The following is a description of a gene set: species: Homo sapiens Human Gene Set: GOCC_GOLGI_APPARATUS A membrane-bound cytoplasmic organelle of the endomembrane system that further processes the core oligosaccharides (e.g. N-glycans) added to proteins in the endoplasmic reticulum and packages them into membrane-bound vesicles. The Golgi apparatus operates at the intersection of the secretory, lysosomal, and endocytic pathways., and this is the list of marker genes: WDR81, B4GALNT4, GABARAPL2, MAN2A1, ST3GAL5, BECN1, DAPK2, LAPTM4A, LPCAT2, ZDHHC5, TSNAX (translin associated factor X), CIMAP3, TRIM22, ARL5C, COP1, TLR8, ZDHHC15, TRAPPC1, MUC7, GNAQ, B4GALNT3, AKT3, ST3GAL6, BIRC6, TRIM23, GCNT1, CABP1, GASK1A, UXS1, PYCARD, NOTCH4, GARIN4, NEDD4L, MAP4K2, MTUS1 (NCBI Gene Id 57509), HLA-DQA1, GORASP2, NUBP1, VAMP7, PPP2R3C, ATP6V0A1, VRK1, AP1M2, GPR107, TPPP, SLC29A3, TAPBPL, GOLT1B, GAPT, RND3, SPRY1, CLTCL1, PI4K2B, SPATA16, ACTL7A, RAB6C, COG5, SEC16B, CLU (clusterin), YIPF3, CACFD1, ATP6V0C, APH1A, SART1, TMEM241, ZDHHC13, ARHGAP32, ATP11A, OPTN (NCBI Gene Id 337928), STEAP2, GOLGA6B, MYMK, RAB3GAP1, DAG1, TRAPPC14, SLC9A7, CD2 (CD2 molecule), TMEM230, CABP2, TPST2, CALN1, FZD8, MBTPS1, TMEM167B, GCNT2, DDX54, FAM241A, ATP8B2, SPPL3, VPS13A (NCBI Gene Id 23230), YIPF4, ENTPD4, LMTK3, VTI1A, CD1C, SCYL1, PISD (phosphatidylserine decarboxylase), CLASP2, MID1, RASIP1, YIPF5 (NCBI Gene Id 81555), SPRR3, KIFAP3, TBC1D22A, ST3GAL3 (NCBI Gene Id 6487), MOSPD1, ARV1, TMEM30A, FAIM2, PLIN3, CD59, JAKMIP2, LEPROT, ATP1A1, PKN3, HS3ST2, GOLGA8B, SCAP, DEFB103B, HID1, CSNK1D, TMCO1, WDR44, STX4, CCDC186, SH3GLB1, GDI1, SRCAP, PITPNB, HLA-H, JAM3, ARF5, DENND4C, ERO1A, SLC10A7 (solute carrier family 10 member 7), COPG1, RAPSN, MANEA, AGRN, MMP11, RAB25, COG7, STMN3, PLSCR1, FCMR, HLA-G, GALNT3, SLC30A1, UNC13B, GDNF, CRHBP, FBXW8, RPGR, C11orf24, RNF24, SLC35A1, ATP2C2, MTCL2, TMF1, WNT5B, M6PR, NOS3, GOLGA8CP, PDGFD, CD3E, FYCO1, MGAT3 (beta-1,4-mannosyl-glycoprotein 4-beta-N-acetylglucosaminyltransferase), MARCHF2, P3H2, BMP1, AKR7A3, WLS, SLC26A11, TNRC6A, FAM114A1, MAP2K2, TLR9, SLC18A3, SEC23A, PANX2, SLC35E2A, ST6GALNAC6, MUC20, LARGE2, TGFB1, CD33, MGAT4A, CDK5RAP2, DIPK2A, TMBIM4, GAD2, SGCD, DEFB103A, GALNT14, MOSMO, DHH, RICTOR, GBGT1, ANGPTL3, PPP1R15A, RHBDF1, ITGA5, RAB11FIP4, TMED9, PAQR8, RAP1GAP, GGA3, GABARAPL1, NAA25, G2E3, GOSR1, CLVS1, SLC35D2, PMF1, MARCHF8, GORASP1, PKD2, STK16, SI, GBP5, AP3B1, RNF121 (ring finger protein 121), TMC6, PI4K2A, SDE2, GOLGA3, MUC4, NIPAL1, DHCR24, SYNE1, B3GALNT1, TRAPPC6B, VIPAS39, KIF13A, GOLGA8R, SSPN, CHST2, NTN3, TMEM87A, B4GALT2, GJA1, PTPRN, RAB14, PDGFC, TRAPPC12, TNKS, RAB26, B3GNT3, VPS13B, B4GALT7, IPO5, MAPK8IP3, GBP4, STX10, FAM234B, MUC12, AMFR, GLT8D1, SNAPIN, GAL3ST1, CCN2, ATP9A, TVP23B, DENND5A, GRM6, STK24 (serine/threonine kinase 24), RHOBTB3, MS4A7, SLC39A11, A3GALT2, RAB11A, APH1B, PROZ, LMAN2L (lectin, mannose binding 2 like), CAV3, MGAT1, IFITM1, APOO, SDC4, MAPK3, SEC14L1, SLC39A7, VPS52, PCSK9, SLC30A7, KDELR2, SGCA, AOC3, LAMP2, BACE2, APBB2, CLVS2, KDELR3 (KDEL endoplasmic reticulum protein retention receptor 3), GALNT8, FGD1 (FYVE, RhoGEF and PH domain containing 1), GLB1, MGAT5B, COPG2, TMEM130, ATP2C1, TICAM2, PKMYT1, GPC6, RAB1B, SLC30A6, RNF115, UBXN2A, FHDC1, MUC6, OPRM1, HRAS, HAS3 (NCBI Gene Id 3038), RIC3, PTCH1, SELENOI, GPR108, POSTN, RAB33B, PKDCC, ARCN1, CTTN, PSEN2, B4GALT5, CD14, BICD2 (NCBI Gene Id 23299), SYNDIG1L, MPPE1, SREBF2 (sterol regulatory element binding transcription factor 2), MOB4, PROC, TJAP1, LRBA, ACBD3, HEPACAM2, NOSIP, ZDHHC6, TBC1D23, PDGFRA, GBP3, DEFB1, ATP6AP2, SEC23IP, WNT7A, LRP6, MTOR, YIF1A, TBC1D4, HLA-DQB2, RAD23A, STX12, B3GALNT2, CD36, PLK3, COPZ2, CST7, GOLGA8Q, MUC13, MYDGF, NAA60, SCOC, ENPP7, ZDHHC3, FTCD, NBN, STK25, TRAPPC13, AGTRAP, COG8 (component of oligomeric golgi complex 8, NCBI Gene Id 84342), CHSY1, APP, CFP, DEFA1B, ARL17B, DUX4, FUT8 (NCBI Gene Id 2530), DCLRE1C, GALNT7, HTT, AGPAT3, GOLT1A, RABEPK, PGAP4, HS3ST3A1, ARFGEF2, TSC2, DOP1A, B4GALT4, RAB34, SCAMP3, KIF1C, GNAI3 (G protein subunit alpha i3), PIK3C2A, GARIN1B (golgi associated RAB2 interactor 1B), UBXN2B, PLD4, RAB33A, LRP1, GBA1, CLTB, GIMAP8, VAMP5, INPP5B, RASGRP1, PITPNM1, STMN4, AKR7A2, BEND5, XYLT2, CLN5, CERKL, NOTCH1 (NCBI Gene Id 54781), SLC9A8, DNM1L, HLA-A, ARMH3, AP1G1, GOLM2, ARF4, CLIC5, VAMP2, ERMAP, PHTF1, ROCK1 (NCBI Gene Id 6093), ZNF622, VAC14, TMED7, PDXDC1, B3GNT5, TNFRSF10A, CHST11, BPNT2, RAB29, SLA2 (NCBI Gene Id 84174), TENM2, DLG1, DEFA5, SYT11, CDK13, CCDC91, CRELD2, ELMOD1, AP4B1, CREB3L4, ST6GALNAC3, PRKN (NCBI Gene Id 8004), ERGIC2, CA4, AP4S1, POMGNT1, C6orf89, HDAC5, TBC1D20, SPPL2B, UMOD, CSGALNACT2, MMP14, RER1, TRAF3IP3 (NCBI Gene Id 80342), NSF, AJUBA, RAB27B, YIF1B, USP33, GNPTAB, ASH1L, SULF1, SLC30A5, VPS33B, CLSTN1, RNASEK, SNAP25, RNF133, NCSTN, SNX1, RNF175, ATP8B1, KDELR1, EBAG9, SLC38A10, SYNRG, B3GALT4, PGAP3, WSCD1 (WSC domain containing 1), DOP1B, ADAM10, SLC2A4, FGF22, FUT6, STX18 (syntaxin 18), MARCHF4, LFNG, LAX1, PLD3, RHOU, MPHOSPH9, LTBR, ZDHHC1, HPD, B3GALT1, EGFR, ARF3, TRAPPC2L, COG4, AGBL4, PAQR4, STX11, CHPF, COPA, ATR, KCNS3, PICK1, LITAF, ACER2, FAT2, LDLRAD4, MAN2A2, HLA-DPA1, GLYCTK, SLC35A4, TRPM4, DPY30, FGF7, TCP1, DEFA6, UGCG (UDP-glucose ceramide glucosyltransferase), SLPI, USP6, COG3, GNPTG, RAF1, RAB27A, LRP2, SPG21, CHAC1, RAB40C, DNM2, CEPT1, PLCE1, TRAPPC8, PROS1 (protein S), AZIN2, ZDHHC2, B3GNT2, GBP1, SECTM1, CTNNA1, PPHLN1, CHST15, GOLPH3, CUBN, ATP8B3, MGAT5, CCDC88A, ARF6, GPC1, GGTA1, MMP16, SLC35G2, HLA-E, DYNC2LI1, COL26A1, SLC30A8, CUL3, B3GNT9, ST8SIA6, FAM20A, UBIAD1, APLP1, QPCTL, BOK, MPLKIP, ABCG1, ECPAS, HLA-F, PHF7, GOLGA8DP, SCAMP4, RAB41, FEZ1, PEX5, KIFC3, KEL, SMPD4, CAV1, HCK, CSDE1, VTN (NCBI Gene Id 7448), PPT1 (NCBI Gene Id 5538), ZG16, TRAPPC4, HS3ST5, TDRD3, NEO1, WNT5A (NCBI Gene Id 7474), GIGYF2, NECAB3, GOLGA8IP, CANT1, KIF20A, TMC8, PLOD2, GOLM1, CRYZL2P-SEC16B, FES, B4GALNT2, EMP2, SLC35C2, CEP85, TBC1D31 (TBC1 domain family member 31), RP2 (NCBI Gene Id 6102), ADAM17, SEMA6D, CLEC18A, RAB20, TREML1 (NCBI Gene Id 340205), IL15RA, ACSL3, RAC1, ERGIC3, PDCD10, SIPA1L3, F8, CAND1, PGAP2, MMP24, WWOX, CSGALNACT1, MYRF, ST6GAL1, DRD2, LRPAP1, PIDD1, TRAPPC11, GPSM1, STX8, CALU, RAB39B, UNC45A, CYTH4, AGRP, GOLGA8G, ATAT1, AP3S1, IGFBP1, TOM1, ATP7B, CABP7, TMED2, FUT1, CNIH1, SAMD8, HOOK3, CHIC2, ARHGEF2, PDE9A, SGSM1, GALT, TRIM7, HLA-DRB4, GDI2, UBAC1, APBA1, PKHD1, CD55, RAB37 (NCBI Gene Id 326624), ARFIP1, SNX9, HUWE1, ADRB2, CTSL, ABO, RGS20, B3GAT2, TMEM165, ZDHHC8, HEATR5B, MSH6, TVP23A, OSBP, NAGPA, RXYLT1, RNF128, NBEA, FGD3, CLEC18C, RAB11FIP5, PRNP, ABCA5, TRIP11, SACM1L, ATP6V0A2, NCAM1, ATL1, SYT1, SEC16A, RAB2A, CEP83, BLZF1, WDFY1, ZDHHC21, GAS6, MANSC1, NEDD4, ST6GALNAC4, GCC1, GOLGB1, UNC93B1, CLTC, ATP9B, NDFIP2, TGOLN2, SLC35B3, TENM1, ATP6V1H, ST6GALNAC5, FGD2, KPNA2, SLC35B4, OCRL, HAS1, ST3GAL4, CFAP410, HLA-DQB1, GCNT7, CD74, SGMS2, PCSK5, SDF4, SGMS1, ARRB1, CHST6, RIC1, F2R, CBY1, AP1AR, MUC19, B4GALT1, VCPIP1, ANK3, FIG4, MAP6, F7, DNMBP, TRAPPC10, SCAMP5, ZDHHC11, STING1, SLC16A13, FZD9, GANAB, CEP128, SFTA2, MSLN, LYPLA2 (lysophospholipase 2), ZDHHC7, TMED10, CDC42, GALNTL6, SLC35B1, CHSY3, UBA5, GBA2, TLR3, BGN, CEP57, RMDN2, AP1B1, CD1E, STRN3, CLCN4, IFT20, CSPG5, MAN1A1, SCYL3, FGD4, OSBPL9, TTC3, IL15, SCAMP1, ATG9A, SUN5, ASIC1, C17orf75, ARL3, SPRING1 (SREBF pathway regulator in golgi 1), CHST14, ARHGAP33, KDR, AP3M1, CHRNA3, RELCH, PSMG1, FUT2, SLC66A2, RAB11B, TBC1D1, GOLPH3L, TBC1D14, ATP8B4, FGFR4, SULF2, LHB (NCBI Gene Id 3972), LIMK2, TLR7, GLG1, PRKAA2 (NCBI Gene Id 5563), MS4A6E, ACO1, GOLIM4, SDC1, HLA-DRB3, TVP23C, ST6GAL2, CD44, CIB1, GARIN3, RAB6B, MDGA1, CEP162, SDC2 (NCBI Gene Id 6383), ZDHHC4 (NCBI Gene Id 55146), PDGFB, DEFA4, RAB11FIP3 (NCBI Gene Id 9727), GOPC, B3GNT7, PXYLP1, CHST9, SLC33A1, MUC16, EXT2, GSAP, S100A3 (NCBI Gene Id 6274), TMEM30B, ATG9B, NMNAT2 (nicotinamide nucleotide adenylyltransferase 2), CLEC2B, GOLGA8J, RTN1, SLC35D3, MBTPS2, RSC1A1, TMED6, PARP10, UST, GKN1, DNAAF2, MARCHF1, SMO, WSCD2, PLEKHA3, RAB39A, PSENEN, SLC35E1, CAPN8, FKTN, SORT1, GALNT5, BSG, MFNG, RFNG, ZDHHC17, CDH1, ZFYVE1, CXCL14, ELANE, F2, NAPEPLD, GIMAP1, SAR1A, ST8SIA3, DSE, DDX31, ST3GAL1, GCC2, PALS1, NMT2, TMEM50B, WDR11, FKRP, SLC26A9, PTGDS, LALBA, PCSK7, ATP11B, PPP2R5C, KRAS, ATP6V1A, ARL5B, MGAT4C, CHPT1, ELMOD3 (ELMO domain containing 3), CD247, ZDHHC18, STK26, GOSR2, MGAT4D, TRAPPC3, NDST2, ARL5A, PHETA1, TMEM59, OMD, GPC2, GAK, PRKG1, CAV2, ALKBH5, RAB38, RGP1, RAB7B, LPCAT1, NPY, SVIP, CDK20, SERINC3, TRRAP, STS, GCNT3, MUC3A (mucin 3A, cell surface associated), LYSET, CD1B, SLC35A3, PLAGL1, WNT6, GRB2, PHAF1, DBNL, SLC1A6, PLOD3, MANEAL, ZNF148, FMOD, STX16, DOCK4, ZDHHC24, MAPKAP1, ATXN2, CHST13, NRAS, GALNT9, COPB2 (COPI coat complex subunit beta 2), SOD3, EI24, MCFD2 (NCBI Gene Id 90411), EVI2A, MYMX, ZDHHC9, BARX2, SH3GL2, NDST3, FGD6, ITM2C, GALNT2, WNT3, COG1, ZDHHC14, TEPSIN, ST8SIA2, SLC35C1, TACC3, CREB3, MGAT2, PTGFRN, NLRP5, YIPF2, FAM91A1, ABCB6, HS3ST1, BCL9, RTN3, ATP1A3, FUT9, LLGL1, RFFL, HS2ST1, SELENOM, NSG1, TAS2R16, SERPINA1, MUC15, FURIN, MUC21, KBTBD8, CLN3, SNCG, GRINA, PPIL2, VCAN, GNAS, ABCC4, CUL7, LYSMD3, GOLGA6D, VPS51, SCAMP2, GOLGA6C, IFT27, POLQ, SLC30A10, OLFM3, TMEM87B, RABGAP1L, ARSL, ASAP1, SHH, NCS1, ABCA7, ATF6B, MMD2, SPINT2, RAB8A, FGFRL1, PRMT5, CLIP3, LMAN1L, CHEK2, CLCN5, ZDHHC11B (zinc finger DHHC-type containing 11B), WDR77 (WD repeat domain 77), CYTH3, PLA2G5, CLSPN, OCIAD1, HLA-C, SLC22A13, VCAM1, OGN, CHST4, AP3S2, LAT, TRAPPC3L, UCHL3, FUT10, GCNT4, CYTH2, MUC5AC, GOLGA5, CYTH1, MLANA, GLT6D1, GFY, PJA2, B3GNT8, FAM3C, GOLGA6L7, RGS19 (regulator of G protein signaling 19), TRIM3, GORAB, TLR6, H1-0 (H1.0 linker histone), ICA1, CNTRL, GDF15, INPP5K (NCBI Gene Id 51763), CBLN3, CNST, ARFRP1 (ADP ribosylation factor related protein 1, NCBI Gene Id 149661), FMNL3, NCAN, ASAP2, EXTL1, PRCD, B4GALT6, DBI, CLSTN2, APOE, HLA-DRA, EHF, FGFR2, MUC5B, ENTPD6, AIMP1, ST3GAL2, YKT6 (NCBI Gene Id 63236), CLDN20, CHPF2, CORO7, CHP1, SELENOK, OCIAD2, GOLGA8K, RAB6A, STC2, MR1, DYNC2H1, KLF5, PI4KB, TM9SF4, NCALD, TMEM132A (transmembrane protein 132A), HLA-DQA2, CPQ, NGF, GOLGA1, CHST5, TMED3, KCNIP3, F10, NDRG2, HS3ST4, COPE, MYOC (NCBI Gene Id 4653), HAS2, ADCY3, RAB1A, SLC35A5 (NCBI Gene Id 55032), RUBCN (NCBI Gene Id 9711), CUX1, HS3ST3B1, SLC5A1, CPTP, VPS45, RRAS2, CREB3L3, PTGES2, PRKCE, TBC1D22B (TBC1 domain family member 22B), STX5, GOLGA8O, SMAD6, ATP7A, TMBIM1, WNT7B, CAMSAP2, MAN1C1, NPC1, PDGFRB, CDH15, ST8SIA4, DYM, PLOD1, MME, YIPF6, ARFGEF1, VPS37C, BGLAP (NCBI Gene Id 632), PLD1, SLC35B2, NOD2, SCYL2, RAB18 (NCBI Gene Id 22931), SH3RF1, DEFB4A, POFUT2, RIT2, PCSK1N (proprotein convertase subtilisin/kexin type 1 inhibitor), GOLGA4, FAM20C, B3GALT2, INPP5E, ZDHHC12, CLSTN3, TGFBI, VTI1B, LGI1, GLA, ARF1, SLC39A9, MAPK15, HLA-DRB5, EMC8, ITM2A, BST2, SNAP29, TMEM45B, ARFGAP1, EIPR1, RAB40A, TP73, EEF1AKMT4-ECE2, AP4E1, MINK1 (NCBI Gene Id 50488), HSPG2, CAMKMT, C1orf43, A4GALT, CDIPT, LGR6, PRAME, USF1, GPR89B, PREPL, HLA-B, MAP6D1, TEX261, RAB7A, SOST, DNAAF6, GALNT18, PNKD, ESCO2, ABCC5, B4GAT1, MICALL1, BCAP31, AP3D1, HHAT, GPC4, APC2, PDGFA, HACE1, PSKH1, LGR5, SCLY, LMAN1, CPE, NAPG, COLEC10, SORL1, TMEM192, VEGFA, GASK1B, PTHLH, MAMLD1, LYN, XYLT1, SERINC5, PDE4DIP, PDE3B (phosphodiesterase 3B), SDCBP2, HLA-DRB1, IFNGR2, OPALIN, SGCB, QSOX1 (quiescin sulfhydryl oxidase 1), RNF149, ELF3, SAR1B, RBFOX1, GALNT1, B4GALNT1, EMID1, SLC35A2, RAB10, ST6GALNAC2, MMD, DDHD2, C1GALT1C1, DYNLT1, MAPRE1 (NCBI Gene Id 22919), PAK4, CLEC16A, TOM1L1, CST3, STMN2, PKD1, SCARB2, ARAP1, GKAP1, LMTK2, MPIG6B, AP3B2, MAN1A2, PMEL, RSAD2, SLC2A1, PACS1, C1GALT1, NDFIP1, COG2, PLEKHM3, TAF11, OTOF, PRELP (NCBI Gene Id 5549), TRIM68, SLC24A5, DYNAP, ERGIC1, GLCE, MYO6, CAMK1G, LRRK2, EXT1, RAB22A, PCSK4, B3GNT6, NLRP2, GBF1 (golgi brefeldin A resistant guanine nucleotide exchange factor 1), CGA, GPR143, RASSF2, PLEKHA8, FUT4, SLC35E4, LARGE1, CLINT1 (clathrin interactor 1), TMED5, RNF148 (ring finger protein 148), SCRG1, NDST1, CD40LG, MARCHF9, ARFGAP3, CD2AP, BCL6, CLTA, HDAC3, DSEL, GIMAP7, PMEPA1, SEC22B, RAB6D, TM9SF2, HERC1, DUSP26, MAN1B1, PLD6, VAPB, MUC17 (mucin 17, cell surface associated), IHH, IRGM, CAPN2, COQ6, PCGF5, KIAA0319L, BIRC7, CHST1, ANGEL1, PRKCI, WNT4, MS4A6A, FUT11, PRKD2 (protein kinase D2), GALNTL5, NAA11, COG6, CHST7, AVPR1B, ABCA12, FUT5, KCNA5, SIX5, YIPF1, GALNT6, GPR89A, ECE2, MALRD1, ZDHHC22, RAB3B, BCAN, NTSR1, ARL1, TIMM50, RIPOR1, GPC5, HS3ST6, TNKS2, MACF1 (NCBI Gene Id 649183), FASN, TPTE2, NSG2, INPPL1, MUC2, FUT7, TMEM167A, RNF144A, GALNT4, TANGO2, GNAI1, TRAPPC6A, VAPA, ABCA6, CHST8 (NCBI Gene Id 64377), PODXL2, ARHGAP21, CHID1, MPL, GOLGA6A, HYAL2 (hyaluronidase 2), STEAP4, RUSC1, ATP8A2, ABCA1, RNF125, GALNT13, LST1, GLT8D2 (NCBI Gene Id 83468), GALNT15, GARIN1A, CCDC170, AP1S2, USP32 (NCBI Gene Id 84669), TMEM79, NLGN1, FGF23, RABEP2, HOOK2, PNRC2, GOLGA2, TMED4, ACP3, RAB32, NUCB2, FUT3, VGF, GAS8, PSEN1, RAB36, FGD5, PIKFYVE, ATF3, IL17RD, SYN1, AP1G2, GAL3ST2, VPS54, DCN, RAB9A, SNTB2, TRAPPC2B, ACHE, MIF4GD, MTTP, KERA, SREBF1, RHBDF2, ACAN, SYBU, HTR7, TNFRSF1A, GRN, NDST4, DAOA, TPP1, COPB1, ASAH2, USO1, BAIAP3, STX6, CHST10, CLBA1, ERC1, TLCD3B, FAM174B, B3GAT3, B3GALT9, HS6ST3, SPP1, ATP8A1, MUC1, MGAT4B, ENTPD7, GALNT17, KLK11, NLRP3, FAM20B, GOLGA8F, LUM, ACER3, SRGN, AP2A1, DRAM2, SORCS1, WIPI1, SDC3, ATF6, PICALM (phosphatidylinositol binding clathrin assembly protein), GFRA1, IFT57 (NCBI Gene Id 55081), MALL, SLC50A1, SYAP1 (NCBI Gene Id 94056), RNF183, NOTCH2, LIPG, CTLA4, ATP6V1D, CCDC88B (NCBI Gene Id 84211), EXTL3 (NCBI Gene Id 2137), DACH1, SLC35E2B, AP3M2, PLPP3, BET1, ZDHHC23, APC, GOLGA8M, TMEM59L, S100A1, GALNT16, KLHL20 (NCBI Gene Id 27252), SPEF2, BACE1, SCARA3, AP1M1, INS, GGNBP1, YIPF7, VAMP3, RAB43, ATP6V0B, RAB12, OBSL1, EXOC3, ALX1 (ALX homeobox 1), RNF122, GBP2, PIK3R1, SLC35D1, RHBDD2, MAP2K1 (mitogen-activated protein kinase kinase 1), SLC11A2, GOLGA7B, B2M, ST8SIA5, CHST3, GALNT10, AHSG, MMGT1, TMED1, MYO18A, TMEM43, ARFGAP2, GOLGA8H, LAP3, GAL3ST4, PHETA2, SERPINB9, CBL, VPS41, BICD1, PERP, CHRM2, HLA-DPB1, FIBIN, GLIPR2, ZDHHC16, PWP1, TAPBP (TAP binding protein), QSOX2, COPZ1, SLC39A13, ITFG2, RAB31, RETREG1, STIP1, AKAP9, SYS1, TENT4A, METTL3, TLR2, TGM4 (NCBI Gene Id 7047), COMMD9, CNTNAP2, B3GNT4, STH (NCBI Gene Id 246744), CHST12, JAKMIP3, SGCE, A4GNT, TRIP10, ST8SIA1, BET1L, PRKD1, B4GALT3, SCFD1, PLLP, NUCB1, GALNT11, TMEM115, PHEX, AQP2, GOLGA8T, TPST1, ATRN, UNC50, ESR1, FNDC3A, FGFR3, NHS, APOA5, ELAPOR1, IER3IP1, SELENOH, ARFIP2, RHOD, OSBPL11, ATP6AP1, RAB13, LMAN2, GOLGA8N, SYT17, MCOLN1, CASD1, CREG2, GGA1, TMEM209, WNT1, CLASP1, PRDM2, CRACR2A, RESP18, PARM1, MYO1B, FAM161A, RAB30, SGCZ, SURF4, VPS53, AP4M1, CSPG4, MARF1, SNX17, SPAG17, LDLR, FZD5, ZFPL1, TBC1D5, WHAMM, KCNJ6 (potassium inwardly rectifying channel subfamily J member 6), B3GAT1, PAQR3, AVPR2, GOLGA8A, ZDHHC19, ICA1L, TRAPPC9, PCSK6, DEFA1, AP1S1, CERT1, LZTR1, NOTCH3, PLA2G4A, B3GALT6, GPER1, RAB2B, GABARAP (NCBI Gene Id 201246), TXNDC8, RHO, SYT4 (synaptotagmin 4), ST6GALNAC1, PRRC1, PDE2A, TLR1, AFTPH, F2RL1, CLEC18B, NSFL1C, NFE2L2, GARIN5A (golgi associated RAB2 interactor 5A), RAB21, DEFA3, VAMP4, AP1S3, GNPNAT1, GPC3, GOLGA8S, CBFA2T3, IGF2R, F9, GALNT12, RPS12, FOLR1, ITM2B, HS6ST2, B3GALT5, TMEM214 (NCBI Gene Id 54867), DPP7, DENND4B, CLCN3, ALB, HIP1, NEDD9, MUCL1, USP6NL, YES1, PLEKHJ1, MAPK1, GGA2, TRAPPC5, SMPD3, WNT3A, SLC35E3, ZDHHC20, TAS1R3, GAL3ST3, GOLGA7, MS4A4A, RHEB, ATP6V1F (ATPase H+ transporting V1 subunit F), CIDEB, TRAPPC2, RABAC1, HS6ST1